The following is a description of a gene set: To identify signature genes that help distinguish (1) sepsis from non-infectious causes of systemic inflammatory response syndrome, (2) between Gram-positive and Gram-negative sepsis. Human Gene Set: GSE9960_GRAM_NEG_VS_GRAM_NEG_AND_POS_SEPSIS_PBMC_DN species: Homo sapiens from publication Payen D, Lukaszewicz AC (PMID 19535937) Genes down-regulated in peripheral blood monocytes (PMBC): Gram negative sepsis versus mixed infection sepsis., and this is the list of marker genes: FDXACB1, ZNF184, ROMO1, COA5, RETREG2, GSTM1, GOLM2, ZNF542P, RUVBL2, PEX12, SERGEF, SLC35B2, ADAM12, PDIK1L, RRP8, BAIAP2-DT, EP400, CHCHD2, CRNKL1, PIK3C2A, KCTD18, IPO8, HAUS3, KLHL15, TMCC1, SPCS1, AASDH, RNF220, GORASP2, PRMT3, NRF1, PPIH, SLC25A43, PWWP2B, NUP133, TCFL5, IGHA1, NDUFB6, SLF1, TNRC6B, ZKSCAN4, CTNND1, CIBAR1, FBXO11, OST4, ANKFY1, ELP1, CCNB1, KIAA1586, ANO6, ZBTB41, BOLA3, NMB, DTWD2, ZNF567, STK32C, RP9P, BRK1, ZNF2, POLR1D, PIGY, TUSC2, HIF1AN, ZNF548, ZNF573, ATP5MJ, SWI5, NAXE, TOMM22, ZNF583, VPS13B, CEPT1, RPUSD2, ZNHIT6, C2CD5, MED23, TMEM42, DET1, C22orf39, ZNF780B, ZNF137P, SMARCD3, SLC22A18AS, CPOX, VPS54, SKIC8, TMEM106B, COX11, NCOA2 (nuclear receptor coactivator 2), SDHAF4, RWDD1, GALNT7, ARRDC3-AS1, CMTM3, CISD3, ALKBH7, GLCE, GPX1, DICER1, PJA1, CRYBG3, MAP1S (NCBI Gene Id 55201), SYTL5, COX16, DAP, BST1, HINT1 (histidine triad nucleotide binding protein 1), ZNF8, GPAM, TRIQK, BPNT1, RBIS, HAT1, NAPEPLD, NENF, POLR3C, ATP6V0E2, SNRPN, ZNF780A, FAAP20, ZNF28, TMEM258, NDUFC1, KLHL7, GSTM4 (NCBI Gene Id 82153), MTCH1, UNC119, GMCL1, TXNDC12, ATAD2 (NCBI Gene Id 84325), FAM199X, ADNP, PSMG3, TPMT, SLC25A39 (solute carrier family 25 member 39), TRUB1, TMLHE, KCTD3, PVALB, RPS18, RCL1, NCSTN, TXNDC17, BAG4, TMEM14B, SSBP3, KMT2C, PTGR2, ANKRD34C, TRIM52, PHPT1, TNKS (NCBI Gene Id 8658), CKMT2-AS1, KIF9, OGFOD3, CSTPP1, CFAP68, LRBA, CDIPT, ZBTB9, HNRNPA3P1, SOS2, SGMS2, INIP, ZRANB1, TNFAIP8L2, SNAP23, RNASEH2B, ETFA, S100PBP, PET117, CCNG1, PSENEN, SDHAF2, CRLS1, ENOPH1, ZFP69B, ARL3, SEPTIN6, TFAM, AGTPBP1, TSEN15, RSL24D1, NIFK-AS1, RNF170, UBE2D4, PSTK, FGFR1OP2, CUL4B (NCBI Gene Id 8450), TFB2M, ZNF473, OGFOD2, ZNF582, RNF111, PGM2, GFM1, ZNF14, ALG5, MRPS16